Given this list of marker genes Nudt8, Acacb, Mlycd, Nudt19, Nudt7, Acaca, here is a description of the gene set: Mouse Gene Set: GOBP_MALONYL_COA_METABOLIC_PROCESS The chemical reactions and pathways involving malonyl-CoA, the S-malonyl derivative of coenzyme A. species: Mus musculus